Given this list of marker genes CDH2, BRSK2, PCDH17, BRSK1, PTEN, NLGN2, here is a description of the gene set: species: Homo sapiens Human Gene Set: GOBP_REGULATION_OF_SYNAPTIC_VESICLE_CLUSTERING Any process that modulates the frequency, rate or extent of synaptic vesicle clustering.